The following is a description of a gene set: Translation factors. studied in species Homo sapiens Human Gene Set: MODULE_149, and this is the list of marker genes: SRP19, EIF3G, EEF1D, EIF3I, EEF1A2, EIF4EBP2, UQCR11, BZW1 (basic leucine zipper and W2 domains 1), HSPB1, EEF1B2, SEC61A1, PABPC1, EIF3E, EIF4B, EIF1, SRP9, SRP54, UQCRB, EIF4G2, UQCRC2, EEF2, EIF4A2, EIF4A1 (NCBI Gene Id 1973), EIF4H, EIF5A, EIF6, EIF3B, UQCRFS1, EEF1G, SRPRA, EIF3C, EEF1A1, SEC11A, UQCRC1, EIF3F, EIF3H, EIF3D